The following is a description of a gene set: Any process that increases the frequency, rate or extent of cell migration involved in sprouting angiogenesis. Cell migration involved in sprouting angiogenesis is the orderly movement of endothelial cells into the extracellular matrix in order to form new blood vessels contributing to the process of sprouting angiogenesis. species: Homo sapiens Human Gene Set: GOBP_POSITIVE_REGULATION_OF_CELL_MIGRATION_INVOLVED_IN_SPROUTING_ANGIOGENESIS, and this is the list of marker genes: MIRLET7F1, RHOJ, HMOX1, GATA2, ANXA1, MIR10A, MIR10B, HDAC9, GREM1, MIR31, ABL1, KDR, PLK2, AKT3, MIR126, HDAC7, VEGFA, MIR101-1, JCAD, MIR23A, CIB1, FGF2, PIK3C2A, PTGS2, NRP1, MIR27A, TGFBR3, MIR150, MIR487B, MIR146A, FOXC2, SRPX2, FGFBP1, NUS1, MIR27B, MIR132, MIR296